Given this list of marker genes Plch2, Plcb3, Pik3cg, Plcb2, Plcb4, Plcl2, Pik3cb, Plcg2, Synj1, Pik3c2g, Pik3ca, Plcl1, Pik3c2b, Pik3c2a (NCBI Gene Id 18704), Pi4kb, Pik3cd, Plch1, Plcg1, Plcb1, Plce1, Pik3c3, Pi4ka, here is a description of the gene set: Mouse Gene Set: GOBP_PHOSPHATIDYLINOSITOL_MEDIATED_SIGNALING The series of molecular signals in which a cell uses a phosphatidylinositol-mediated signaling to convert a signal into a response. Phosphatidylinositols include phosphatidylinositol (PtdIns) and its phosphorylated derivatives. studied in species Mus musculus